The following is a description of a gene set: Chemotherapy with the alkylating agent BCNU (1,3-bis (2-chloroethyl)-1-nitrosourea) is the most commonly used chemotherapeutic agent for gliomas. However, the usefulness of this agent is limited because tumor cell resistance to BCNU is frequently found in clinical brain tumor therapy. The O6-methylguanine-DNA methyltransferase protein (MGMT) reverses alkylation at the O6 position of guanine and we have reported the role of MGMT in the response of brain tumors to alkylating agents. However, the different mechanisms underlying the patterns related to MGMT remain unclear. To better understand the molecular mechanism by which BCNU exerts its effect in glioma cell lines according MGMT expression, we used microarray technology to interrogate 3800 known genes and determine the gene expression profiles altered by BCNU treatment. Our results showed that treatment with BCNU alters the expression of a diverse group of genes in a time-dependent manner. A subset of gene changes was found common in both glioma cell lines and other subset is specific of each cell line. After 24 h of BCNU treatment, up-regulation of transcription factors involved in the nucleation of both RNA polymerase II and III transcription initiation complexes was reported. Interestingly, BCNU promoted the expression of actin-dependent regulators of chromatin. Similar effects were found with higher BCNU doses in MGMT+ cell line showing a similar mechanism that in MGMT-deficient cell with standard doses. Our data suggest that human glioma cell lines treated with BCNU, independently of MGMT expression, show changes in the expression of cell cycle and survival-related genes interfering the transcription mechanisms and the chromatin regulation. Human Gene Set: BANDRES_RESPONSE_TO_CARMUSTIN_WITHOUT_MGMT_48HR_DN species: Homo sapiens from publication Bandres E, Andion E, Escalada A, Honorato B, Catalan V, Cubedo E, Cordeu L, Garcia F, Zarate R, Zabalegui N, Garcia-Foncillas J (PMID 15980968) Genes down-regulated in A172 cells (glioma, does not express MGMT) by carmustine at 48 h., and this is the list of marker genes: INSL3, NRTN, AMH, PFN1, SHOX, PMS2P11, LRCH4, ADCYAP1, ACTC1, GTF2F1, ACTN1, MDK, IRS1 (insulin receptor substrate 1), HMGN2, TUBG1, INSIG1, ATP1A3, MAP4K2, EPHX1, WIPF1, YWHAH, ADRA1B, ITGA3, PPM1G, FBN1, ATP5F1D, KRT17, SEPTIN5 (NCBI Gene Id 5413), FYN, AQP8, INPPL1, LOXL1